Given this list of marker genes Dusp2, Xiap, Tpx2, Jup, Cltc, Jak2, Chil5, Prkar2b, Fbxo5, Mlxipl, Becn1, Prpsap1, Cdkn1a, Kcnq3, Map3k7, Nek6, Elp2 (elongator acetyltransferase complex subunit 2), Ppp1r12c, Cdc5lrt7, Sh2b2, Rela, Trib1, Midn, Cdc42 (NCBI Gene Id 12540), Rnf138rt1, Ncs1, Frs3, Fam83b, Tbl2, Jtb, Hnrnpa0, Pik3r2, Axin2, Nek9 (NCBI Gene Id 353030), Socs1 (NCBI Gene Id 12703), Lsm2, Tesk1, Nap1l1, Srcin1, Ankra2, Tob1, Dusp19, Rac2, Rhoj, Tsks, Pfkl, Sox9, Naip6, Nr4a3, Pfkm, Rhog, Trem2, Prkar2a, Ptpn22, Plk2, Aurkb, Cep43, Hif1a, Aatf, Cadm4, Mob4, Jakmip3, Sh2d3c (NCBI Gene Id 27387), Cdkn2d, Atn1, Stk11ip, Alkal1, Pea15b-ps (proliferation and apoptosis adaptor protein 15B, pseudogene), Rhoh, Ptafr, Trim30a, Chp1, Atf7, Lrrc14, Ppp1r9a, Acsl3, Arhgef16, Cdkn2a, Dnm3, Add3, Cbl, Gdnf, Taok1, Mical1, Parp16 (NCBI Gene Id 97537), Rgs4, Irak4, Itgb2, Rgcc, Trim30d, Trp53, Kif20a, Pawr, Nbea, Cdc25c (NCBI Gene Id 12532), Akt2, Ctnnb1, Cry2, Map2, Ghr, Tcl1b5, Kif5b, Oxsr1, Flna, Lrba, Cdk9, Bora, Ankrd2, Irf5, Stk38, Cnksr2, Rps6, Golga2 (NCBI Gene Id 99412), Traf6, Stat3, Dnajc3, Myh6, Wwc2, Grin2b, Ppp1r15a, Acp4, Pea15a, Esr1, Mycn, Brsk2, Ccnt1, Bcl2l1, Gstp2, Angpt2, Bag5, Prr7, Sufu, Acvrl1, Fbxw5, Tcf3, Grb7, Taok2, Cdk5rap2, Aurka, Stxbp1, Git1, Mapk8 (mitogen-activated protein kinase 8), Dact3, Ptpn5, Ror2, Rack1, Gja1, Tjp2, Foxa2, Actbl2, Lats1, Slc12a7 (NCBI Gene Id 52539), Parp1, Dnaja3, Dgkd, Smad3, Prkce, Nsf, Nedd9 (NCBI Gene Id 319669), Atp1b1, Traf4, Ttn, Prkcsh, Arrb1, Il15ra, Rhof, Dusp12, Prlr, Flt3l, Grb2, Rps18, Rhoq, Adcy4, Pbp2, Mapkapk2, Cd6, Dnm2, Tax1bp1, Pih1d1, Sorbs1, Llgl1, Ppp1cc, Prkab1, Irs2, Ubqln1, Map3k12, Map3k5, Racgap1, Naip1, Chek2 (checkpoint kinase 2), Mapk9, Gskip, Cacnb3, Ldha, Ccdc88a, Mapt, Gprc5b, Rnf138, Cntln, Srsf2, Ifnar2, Cavin3, Myom1, Actg1, Pitpnm2, Spred2, Rps3, Ctnnd1, Bcl2l11, Pip5k1a, Nbeal2 (neurobeachin-like 2), Ikbkb, Inka2, Ace, Chrna7, Dact1, Cnppd1, Spred3, Cblc, Spry2, Tbc1d14 (TBC1 domain family, member 14), Rgs14, Crk, Fgr, Stx17, Rac1, Cep152, Tbr1, Ppp1ccb, Plk1, Ugt1a10, Spag16, Vrk1, Cav1, Ptn, Ptprr, Faf1, Copb2, Ksr2, Trim12a, Gas6, Gsn, Ap2a1, Tom1l2, Ccnb1, Cyld, Rad54l2, Ptpn1, Pdcd10, Eef2, Psg29, Bcl2l14, Kcnq1, Dazap2, Npm1, Srsf1, Hdac4, Atp1a1, Cass4, Ctbp2, Sv2a, Cebpb, Plg, Sit1, Rnd3, Rab11fip2, Tpcn2, Bcl10, Trib2, Trim8, Ldhb, Slc22a8, Trim5, Artn, Shc1, Per3, Fam83c, Irgm2, Gsk3b, Dscam, Kif11, Gab2, Spdya, Appl1, Map3k1 (NCBI Gene Id 26401), Trim43c, Dlg4, Inka1, Mvp, Tfrc, Ticam1, Cit, Tcl1, Bank1, Hspb1, Cenpe, Stub1, Eif3a, Khdrbs1, Syk (spleen tyrosine kinase), Prkaca, Nbr1, Ntrk2, Rhobtb1, Bcar3, Fam83a, Lims1, Tnip1, Tnfaip3, Mapre1, Wdr45, Ufl1, Crkl, Rab13 (RAB13, member RAS oncogene family), Msn, Cimap3, Ugt1a7c, Prkag2, Rab8a, Rhov, Mapre3, Rps19, Gstp1, Tcl1b1, Gp6, Slc12a5, Ntrk1, Nox4, Gata4, Rhod, Agtr1a, Mapkapk5, Pola1, Plek, Grin2a, Sirpa, Pdlim5, Myh9, Dusp22, Gcsam, Cebpa, Pebp1, Plcb4, Tns2, Pdpk1, Myo5a, Brsk1, Frs2, Lrrc7, Cir1, Lin7b (lin-7 homolog B, crumbs cell polarity complex component), Dsp, Unc5c, Syn1, Dnm1, Tdg, Slc2a3, Calm1, Nrp1, Htt, Camk2n1, Dlg1, Cd226, Mapkapk3, Ep300, Top2a, Elmo2, Erbb2, Cdc5lrt9, Adcy6, Chil4, Bcar1, Ceacam10, Bcl11a, Lck, Mlkl, Rara, Zc3hc1, Ms4a2, Phyhip, Ibtk, Gckr, Strip1, Atf2, Fcrl5, Dock4, Nos1ap, Dnm1l, Rps6ka3, Prkcz, Qars1, Trip4, Sh2b3, Mapk7, Rffl, Ercc6l2, Ptk2, Apba1, Kiz, Socs5, Hdac5, Eef1a1, Fam83d, Src, Cd28, Skap1, Pin1, Pin1rt1, Nck2 (NCBI Gene Id 74592), Kat2b, Prkar1a, Cacnb2, Mapk8ip3, Jakmip1, Glrx3, Anxa5, Sos1, Smim26, Rb1, Xbp1, Prkcb, Dixdc1, Tcl1b4, Nrg1, Acaca, Relb, Add2, Irak3, Dok2 (NCBI Gene Id 13449, docking protein 2), Ceacam1, Irak1, Vdac1, Itgb2l, Mst1, Angpt1, Kidins220, Cacnb4 (calcium channel, voltage-dependent, beta 4 subunit), Ppp1cb, Raf1, Braf, Rptor, Nefh, Cdk5, Grb14 (growth factor receptor bound protein 14), Kcnh1, Tcf7l2, Mtcp1, Ilk, Pxn, Strada, Prkag3, Cdc5l, Prmt1, Ppp2ca, Mapkap1, Scrib, Arrb2, Hyal2, Ugt1a9, Mycs, Laptm4b, Nol3, Pgam1, Chia1, Slc12a2 (NCBI Gene Id 20496), Ccna2, Snai1, Arhgdia (NCBI Gene Id 77176), Ank2, Trap1, Slc12a4, Ccnk, Akap5, Prkd1, Il12rb2, Dlg2, Cdc5lrt6, Mapre2, Mtor, Pdgfrb, Kif2a, Prkra, Ywhaz, Tab1, Tnni3, Cdc5lrt8, Trim6, Sirt1, Ccny, Camk2n2, Maml1, Vim, Trim43b, Cblb, Itgav, Dpysl2, Stx1b, Stap1, Trim43a, Cd8a, Pten, Sfn, Pak2, Pink1, Rasgrp3, Foxm1, Acvr1, Rbbp6, Parp8, Nck1, Ccne1, Cdc5lrt1, Actb, Dele1, Akap1, Casp9, Wdcp, Camk2b, Pak1, Casq2, Smcr8, Cab39, Fzd5, Firrm, Prkar1b, Irgm1, Gch1, Igsf9b, Park7, Spred1, Rad23a, Arhgap33, Hcls1, Spag9, Fam83e, Cdk5r2, Kcna5, Adipor1, Smo, Snap91, Cks1b, Cask, Dusp3, Trpv4, Axin1, Musk, Ptprc, App, Casr, Zbtb4, Stx1a, Csk, Ceacam2, Zfp36, Gata6, Prkag1, Fam83h, Telo2 (NCBI Gene Id 71718), Ulk1, Itgb1, Trib3, Pram1, Kif1b, Cdc25b, Mapk6, Tom1l1, Ttc28, Ppef2, Cdk5rap3 (NCBI Gene Id 97738), Traf3, Pcna, Akt1, Dgkq, Arhgef7, Foxo3, Stau2, Gfap, Cdc25a, Rhoc, Angpt4, Ppara, Itgax, Naip2, Map2k3, Prc1, Psg22, Cspg4, Ap1b1 (adaptor protein complex AP-1, beta 1 subunit), Dvl2, Chil6, Nell2, Fermt2, Mapk4, Rps6-ps4, Spdye4b, Myom2, Cd4, Traf2, Prkg1, Prkch, Map2k1, Cd247, Rasgrf1, Gria1, Cdk13 (cyclin dependent kinase 13), Prkab2, Sp100, Dusp1, Rims1, Ceacam20, Ptprf, Cib1, Bicd1, Sgo1, Cav2, Dusp10, Calm3, Cdc37, Tgif1, Eef1a2, Cdkn2c, Prkd2, Usp37, Hsf1, Mical2, Cd44, Insr, Bmpr2 (bone morphogenetic protein receptor type 2), Dvl1, Twf2, Lmnb1, Ccr5, Psg18, Cdkn1b, Cdk12, Zpr1, Rictor, Ccnd3, Grm5, Trp73, Gria2, Map4k2, Dnajb2, Fnta (NCBI Gene Id 14272), Nme1, Plcg1, Trim30c, Akap7, Akt3, Gstm1, Ppm1d, Tpr, Sqstm1, Shc3, Wwc1, Adam10, Map2k7, Tuba4a, C1qbp, Cdk5r1, Ppp1r9b (NCBI Gene Id 217124), Adra2a, Lime1, Acta2, Trim12c, Ptprk, Rasa1, Rad9a, Rnd1, Ezr, Ptpn11, Dlg3, Ppp1r12b, Tnip2, Emp2, Ptpn6, Pick1, Tirap, Tfpt, Atp2b4, Fez1 (NCBI Gene Id 235180), Mapk1, Sike1, Gsk3a, Daxx, mt-Nd2, Tsacc, Ppme1, Ccnd2, Map2k6, Iqsec1, Cavin2, Pax6, Rcc2, Lipe, Slc12a6, Cdh2, Chil3, Hes1, Pla2g6, Klrk1, Parp6, Tradd, Atf5, Cks1brt, Pspn, Usf1, Mapk8ip2, Cdc5lrt4, Cdkn2b, Acte1, Parn, Slc2a1, Ccnd1, Rnd2, Itgb3, Igtp, Pfkfb2, Opa1, Trip6, Fmr1, Dcx, Pja2, Vrk2, Mef2a, Naip5, Cd24a, Igbp1, Cnot9, Scn5a, Ywhag, Cdc6, Spdye4c (NCBI Gene Id 640719), Rnf13, Nr3c1, Rb1cc1, Was, Myoc, Kif14, Nod2, Epha1, Pkd1, Pik3r1, Pld2, Cenpj, Stk39, Cacul1, Mag, Ptprj, Nbeal1, Agap2, Atf4, Pkn1, Ccnb1-ps, Rheb (Ras homolog enriched in brain), Ccnt2, Hdac7, Ppp2r5a, Ugt1a8, Cdh5, Bad, Abl1, Pam, Alkal2, Sting1 (NCBI Gene Id 72512), Dgkh, Pfkfb1, Dok7, Pde8a (phosphodiesterase 8A), Ap2a2, Lrp4, Marcks, Pitpnm1, Tex14, Shc2, Marveld3, Tgfbr2, Pkia, Ryr2, Rhobtb2, Rab3il1, Dact2, Hsp90ab1, Prkg2, Irs1, Dctn2, Dctn1, Cadps, Gdf3, Nfatc1, Frmd5 (FERM domain containing 5), Fam83f, Spdye4a, Ldb3, 4930544G11Rik, Fam83g, Elavl1, Ptpn23, Tcl1b2, Adam9, Mad2l2, Epha4, Sgk1, Sh3gl2 (SH3-domain GRB2-like 2), Zfyve26, Prkaa1, Akap11, Prkcd, Itgb1bp1, Sash1, Ppp1r12a, Pitpnm3, Atg13, Polr2a, Sipa1l1, Casp1, Prdx3, Fas, Lax1, Mob1b, Dab2ip, Gfral, Sdc4, Gadd45a, Rapgef2, Rnf41, Shc4, Macroh2a1, Plcg2, Ptpn2, Clasp2, Cpne3, Hpca, Srebf1, Blnk (NCBI Gene Id 17060), Trim72, Srsf5, Cep68, Fiz1, Fbxo7, Sh2b1, Pkp2, Ccne2, Sik1, Mapk8ip1, Apc, Ski, Pde3b, Rhou, Wnk1, Ptk2b, Nell1, Iqgap1, Mapk14, Egfr, Hdac9, Hspb6, Tcl1b3, Per2, Syngap1, Spg11, Prkrip1, Cd160, Nos2, Dusp16, Tollip, Bace1, Cdh1 (cadherin 1), Per1, Exoc2, Wars1, Smad1, Ptpn14, Map3k11, Calm2 (calmodulin 2), Cry1, Tprkb, Piwil1, E2f1, Rbck1, Kif13b, Cdc5lrt10, Cd2, Ksr1, Eif4enif1, Prkn, Nrtn, Cacnb1, Rac3, Cks2, Trim30b, Mavs (mitochondrial antiviral signaling protein), Lat, Utrn, Map3k2, Rps7, Tiam1, Rhoa, Atg101, Errfi1, Cdc5lrt5 (NCBI Gene Id 668198), Thy1, Hsp90aa1, here is a description of the gene set: species: Mus musculus Mouse Gene Set: GOMF_KINASE_BINDING Binding to a kinase, any enzyme that catalyzes the transfer of a phosphate group.